The following is a description of a gene set: Th1 and Th2 cells arise from a common precursor cell in response to triggering through the TCR and cytokine receptors for IL-12 or IL-4. This leads to activation of complex signaling pathways, which are not known in detail. Disturbances in the balance between type 1 and type 2 responses can lead to certain immune-mediated diseases. Thus, it is important to understand how Th1 and Th2 cells are generated. To clarify the mechanisms as to how IL-12 and IL-4 induce Th1 and Th2 differentiation and how TGF-beta can inhibit this process, we have used oligonucleotide arrays to examine the early polarization of Th1 and Th2 cells in the presence and absence of TGF-beta after 0, 2, 6 and 48 hours of polarization. Human Gene Set: GSE2770_TGFB_AND_IL4_VS_IL12_TREATED_ACT_CD4_TCELL_2H_UP from publication Lund R, Aittokallio T, Nevalainen O, Lahesmaa R (PMID 14607935) studied in species Homo sapiens Genes up-regulated in CD4 T cells activated by anti-CD3 and anti-CD28: TGFB1 and IL4 (2h) versus IL-12 (2h)., and this is the list of marker genes: PRM3, FAP, ASB9, PIGC, SLC25A14, LINC00917, PNPO, ANAPC5, ELAVL2, NIPAL1, SLC25A4, CTDSP2, PDCD6IP, SCN1A, NUP214, NGFR, TMEM204, HACD4, MMP19, NSA2, CEP44, LINC00310, MAP2K6, MPRIP, PURG, C11orf21, LONRF2, TRIM37, KLK5, NLRP11, KAT8, SNHG29, MRPL42, RAD51D, RPL13A, RBM19, VENTX, EIF5A2, INSL6, ITGA6, TCEA1, WDR1, MORF4L2-AS1, RNPC3, RPL7A, HDAC8, COL19A1, NAT10, EEF1B2, SH3BP5, LIMS1, RMDN1 (regulator of microtubule dynamics 1), SNHG6, ZFP64, ST7L, NT5M, KIFAP3, COX7C, HEXIM2, EIF3F, LINC01312, EIF3D, TANC1, KCNJ5, GMFG, HUS1, FSTL4, AGO1, ZFAS1, ARMC12, GPR137C, SRI, IDO1, DNAJC14, LDLRAD4-AS1, PIBF1, SMG8, TTLL5, NAAA, APEX1 (apurinic/apyrimidinic endodeoxyribonuclease 1), NDUFAF5, EBPL, CYB5R4, EIF2B2, LRIG3, OSBPL9 (NCBI Gene Id 79638), CABS1, OLR1, ERICH1, SFXN4, OR7C2, SNHG32, NDUFA10, GTF2E2, TYSND1, HAUS4, CSTF1, RAP1GAP2, RAB28, ZFAND1 (NCBI Gene Id 79752), MCUB, DHRS11, CORIN, LRRTM4, TKT, DDX11, TIGD1, PHF10, FAM151A, MAGEB6, ATP1A1, PHIP, DGKH, TANC2, PLA2G12A, TNNI3K, COX6C, CTSE, ZNHIT3, VPS72, ZNF414, POU6F2, ADA, RPL32, RHOT2, SNX4, MAP2K4, SH3BP1, RPL12, THOC5, RASA3, HDDC2, GABRA2, RBPMS2, SLCO3A1, ARPC5, LINC00628, TYW3 (tRNA-yW synthesizing protein 3 homolog), ABHD11 (NCBI Gene Id 83451), ENTHD1, FAM217B, INIP, RPL19, MAGI2-AS3, GNG10, TAPT1, CCL25, OPA1, RPL29, MSL1, BLMH, TMCO1-AS1, UFC1, NHLRC3, TSPAN18, TMSB15B-AS1, GYPC, ENSG00000288891, WASF3, DRG2, USF2, MAP1A, ACTMAP, SNAPC5, ING1, HMX2, TXK, DUSP7, RPL35A, ADAM20, AGBL5, MARS2, CRIPT, MAP7D1, RPS15A, POLR1D (RNA polymerase I and III subunit D), RCSD1, OBP2A, LST1, WFDC10A, FAM236A, RPL11, XGY2, RENBP, AGMAT, CRCP, ZNF41, METTL21A, SLC35F1 (NCBI Gene Id 222553), DNAJA3, RPL15, FLOT2, EPHA1, GABRG1, RPL3, NACA, HGFAC